Given this list of marker genes CTTN, LAMC2, MYBL2, AURKA (aurora kinase A), FGF4, TOP2A, PTGS2, NCOA3, PAK1, CCND1, PTK2, CSE1L, E2F5, EXT1, CYP24A1, FGF3, ERBB2, MT-CO2, LRRC32, TGFB2, THRA, MED1, PTPN1, MOS, MYC, TNFRSF6B, ZNF217, PEBP1, here is a description of the gene set: from publication Chin SF, Wang Y, Thorne NP, Teschendorff AE, Pinder SE, Vias M, Naderi A, Roberts I, Barbosa-Morais NL, Garcia MJ, Iyer NG, Kranjac T, Robertson JF, Aparicio S, Tavaré S, Ellis I, Brenton JD, Caldas C (PMID 17001317) We analysed 148 primary breast cancers using BAC-arrays containing 287 clones representing cancer-related gene/loci to obtain genomic molecular portraits. Gains were detected in 136 tumors (91.9%) and losses in 123 tumors (83.1%). Eight tumors (5.4%) did not have any genomic aberrations in the 281 clones analysed. Common (more than 15% of the samples) gains were observed at 8q11-qtel, 1q21-qtel, 17q11-q12 and 11q13, whereas common losses were observed at 16q12-qtel, 11ptel-p15.5, 1p36-ptel, 17p11.2-p12 and 8ptel-p22. Patients with tumors registering either less than 5% (median value) or less than 11% (third quartile) total copy number changes had a better overall survival (log-rank test: P=0.0417 and P=0.0375, respectively). Unsupervised hierarchical clustering based on copy number changes identified four clusters. Women with tumors from the cluster with amplification of three regions containing known breast oncogenes (11q13, 17q12 and 20q13) had a worse prognosis. The good prognosis group (Nottingham Prognostic Index (NPI) <or=3.4) tumors had frequent loss of 16q24-qtel. Genes significantly associated with estrogen receptor (ER), Grade and NPI were used to build k-nearest neighbor (KNN) classifiers that predicted ER, Grade and NPI status in the test set with an average misclassification rate of 24.7, 25.7 and 35.7%, respectively. These data raise the prospect of generating a molecular taxonomy of breast cancer based on copy number profiling using tumor DNA, which may be more generally applicable than expression microarray analysis. Human Gene Set: CHIN_BREAST_CANCER_COPY_NUMBER_UP Genes from common regions of gains observed in more than 15% of 148 primary breast cancer tumors. species: Homo sapiens